Given this list of marker genes C18orf21P1, E2F2, STAT6, OTOS, UAP1, PFKM, ZNF567, TAGLN2P1, FABP5P7, SNX16, OSBPL9, CLCN5, ZNF561-AS1, MPPE1, OMG (oligodendrocyte myelin glycoprotein), BBC3, ERICH1, CCL8, SATB1-AS1, WWP2, COX16, SRGAP1, OSMR, UHRF1, ZNF45, NAXD-AS1, LYPLA2P3, LINC00431, RPL7AP70, GSTO1, here is a description of the gene set: studied in species Homo sapiens Genes containing one or more binding sites for (ZNF26) in their promoter regions (TSS -1000,+100 bp) as identified by GTRD version 20.06 ChIP-seq harmonization. from publication Yevshin I, Sharipov R, Kolmykov S, Kondrakhin Y, Kolpakov F (PMID 30445619) Human Gene Set: ZNF26_TARGET_GENES